The following is a description of a gene set: Any signaling pathway that modulates the activity of a cell cycle cyclin-dependent protein kinase to modulate the switch from G1 phase to S phase of the cell cycle. Human Gene Set: GOBP_REGULATION_OF_CELL_CYCLE_G1_S_PHASE_TRANSITION studied in species Homo sapiens, and this is the list of marker genes: PSME1, FGF10, RBL1, ARID2, ANKRD17, MIR451A, PAGR1 (PAXIP1 associated glutamate rich protein 1), TCIM, ARID1B, SMARCE1, SENP2, SMARCD3, PLK3, KIF14, TFDP3, MIR208A (NCBI Gene Id 406990), CRLF3, TBX2, MYO16, MIR29A, PLCB1, KLF4, MIR495, CCND2, MIR221, EIF4G1, MIR133B, TMSB4X, RASSF1, CENPJ, BCL7A, ACVR1, FAM107A, MIR638, MIR26A1, MIR15B, ACTL6A, PTPN6, KCNA5 (potassium voltage-gated channel subfamily A member 5), CRNN, MIR193A, RFWD3, PLCG2, MLF1, PRMT2, CCNE2, MDM2, APPL2, LSM10, CDKN1B, PTENP1-AS, CTDSPL, SMARCA4, PHF10 (PHD finger protein 10), TRIAP1, TFDP1, ZNF655, E2F1, MIR29C, EZH2, TRIM39, DPF2, MIR29B1 (microRNA 29b-1), BRD7 (bromodomain containing 7), STOX1, CDK2AP2, PBRM1, RBL2, MIR16-1, SMARCB1, DLG1, SMARCC1, MIR892B, MIR362, GIGYF2, TP63, FAM83D, RB1, TMEM14B, STIL, CDKN2B, DDX3X, WAC, DGKZ, ACTL6B, MIR15A, CYP1A1, E2F7, CDC6, INO80, MNAT1, ATP2B4, AIF1, FHL1, LSM11, RDX, PKP3, APPL1, MIR214, EGFR, DACT1, SMARCC2, RPTOR, ARID1A, AKT1, RRM1, ADAM17, TP53, MUC1, CTDSP2, RGCC, ANXA1, FBXO31, PSME3, DDRGK1, BCL7C, BCL2, TAF1, ECD, APC, MEPCE, BCL7B, SMARCD2, PSME2, PKD1, APBB1, MIR520A, CDK2, MIR519D, PKD2, MIR372, CCL2, MIR30C2, MIR133A1, SASS6, JADE1, SMARCD1, MIR10A, PRKDC, MIR520H, CDK10, CCND3, PPP2CA, TCF3, DPF1, MIR873, PLK5, ADAMTS1, FBXW7, CDKN2C (NCBI Gene Id 654235), CDKN1A (NCBI Gene Id 1026), FBXO7, CTDSP1, PAF1, DPF3, ZC3H12D, BTN2A2, KANK2, TREX1, KLF11, MIR222, UBE2E2, SLFN11, MTBP, ACTB, AMBRA1, PLRG1, MIR515-1, DCUN1D3, RPA2, MIR503, CDKN2A, BID, RPS27L, CDKN2D, MN1, SDE2, GPR15LG, TERT, SOX2, KMT2E, CDK7, SUSD2, DDR2, WEE1, STXBP4, NANOGP8, CUL4B (cullin 4B), GPNMB, RRM2, CCND1, TM4SF5, CCNH, GLI1, MIR137, SMARCA2, CACNB4, CCNE1, CPSF3 (cleavage and polyadenylation specific factor 3), PTEN, ID2, CDC73, GFI1B, INHBA, MBLAC1, CUL4A